Given this list of marker genes PMFBP1, LHB, AR, SUN5, MAMLD1, here is a description of the gene set: Androgen insufficiency Insufficient amount of androgenic activity. species: Homo sapiens Human Gene Set: HP_ANDROGEN_INSUFFICIENCY